Given this list of marker genes LRGUK, ZNRF3, FBN2, CCDC3, FCGR1BP, PSEN1, ZFHX4, SMIM10, PTPRJ (NCBI Gene Id 5795), ZNF568, NUTF2 (nuclear transport factor 2), PSG8, MRPL20, GHITM, ASB8, HCN1, TRIM10, STK39 (serine/threonine kinase 39), EGR2, TEAD4, COL1A1, LMLN, HOXA1, ARK2C, ECHDC1, TENM3, FGA, CLEC4D, THBS4, CPNE8, CHST11, MANBAL, CHERP, RNF10, ZBTB1, ATXN1, TEAD1, here is a description of the gene set: studied in species Homo sapiens from publication Chen Y, Wang X (PMID 31504780) Genes predicted to be targets of miRBase v22 microRNA hsa-miR-3940-5p in miRDB v6.0 with MirTarget v4 prediction scores > 80 (high confidence targets). Human Gene Set: MIR3940_5P